The following is a description of a gene set: The live vaccine strain (LVS) of Francisella tularensis is the only vaccine against tularemia available for humans, yet its mechanism of protection remains unclear. We probed human immunological responses to LVS vaccination with transcriptome analysis using PBMC samples from volunteers at time points pre- and post-vaccination. Gene modulation was highly uniform across all time points, implying commonality of vaccine responses. Principal components analysis revealed three highly distinct principal groupings: pre-vaccination (-144 h), early (+18 and +48 h), and late post-vaccination (+192 and +336 h). The most significant changes in gene expression occurred at early post-vaccination time points (<=48h), specifically in the induction of pro-inflammatory and innate immunity-related genes. Evidence supporting modulation of innate effector function, specifically antigen processing and presentation by dendritic cells, was especially apparent. Our data indicate that the LVS strain of F. tularensis invokes a strong early response upon vaccination. This pattern of gene regulation may provide insightful information regarding both vaccine efficacy and immunopathogenesis that may provide insight into infection with virulent strains of F. tularensis. Additionally, we obtained valuable information that should prove useful in evaluation of vaccine lots as well as efficacy testing of new anti-F. tularensis vaccines. species: Homo sapiens from publication Fuller CL, Brittingham KC, Porter MW, Hepburn MJ, Petitt PL, Pittman PR, Bavari S (PMID 17349694) Human Gene Set: FULLER_PBMC_F_TULARENSIS_VACCINE_LVS_AGE_22_54YO_192HR_UP Genes up-regulated in peripheral blood mononuclear cell 192h vs 0h in adults (22-54) after exposure to F. tularensis vaccine LVS, time point 192H, and this is the list of marker genes: IRAK1BP1, IRAK2, TLR8, TLR3, DCP1B, CCL22, TLR4, DCTN2 (NCBI Gene Id 1640), IRAK4, ADAM11, CD86 (NCBI Gene Id 942), HLA-DMA, TLR10, CCR5, ICAM2, TLR9, CARD9, TIRAP, TRAF6, TLR7, HLA-DRB1, CCL16 (NCBI Gene Id 6360), LILRB4, TLR6, TLR2, TAP1, CCL21, CD1C, TLR1, CD81, NOD1, FCGR1A, MYD88, CCR2, CD1B, CARD14, CD1A, HLA-DQB1, CARD10, NOD2, CCR4, TLR5, CD1D (NCBI Gene Id 912), ADAMDEC1, CARD8